The following is a description of a gene set: Genes positively differentially expressed in cell type: NK cell upon treatment with cytokine: IL-9 in mouse lymph nodes in vivo. studied in species Mus musculus from publication Cui A, Huang T, Li S, Ma A, Pérez JL, Sander C, Keskin DB, Wu CJ, Fraenkel E, Hacohen N (PMID 38057668) Mouse Gene Set: CUI_NK_CELL_IL9_RESPONSE_UP Cytokines mediate cell-cell communication in the immune system and represent important therapeutic targets. A myriad of studies have highlighted their central role in immune function, yet we lack a global view of the cellular responses of each immune cell type to each cytokine. To address this gap, the authors created the Immune Dictionary, a compendium of single-cell transcriptomic profiles of more than 17 immune cell types in response to each of 86 cytokines (>1,400 cytokine-cell type combinations) in mouse lymph nodes in vivo. A cytokine-centric view of the dictionary revealed that most cytokines induce highly cell-type-specific responses. For example, the inflammatory cytokine interleukin-1β induces distinct gene programmes in almost every cell type. A cell-type-centric view of the dictionary identified more than 66 cytokine-driven cellular polarization states across immune cell types, including previously uncharacterized states such as an interleukin-18-induced polyfunctional natural killer cell state., and this is the list of marker genes: Pfn1, B2m, Gzmb, Pdia3, Erh